Given this list of marker genes Gnb3, Gng8, Gng11, Plcb3, Gng7, Gnb2, Gng5, Gngt2, Gng10, Gng3, Gng4, Gngt1, Gnb5, here is a description of the gene set: Reactome Pathway: G beta:gamma signalling through PLC beta studied in species Mus musculus part of: G-protein beta:gamma signalling electronically inferred by orthology from the curated human pathway This event has been computationally inferred from an event that has been demonstrated in another species.<p>The inference is based on the homology mapping from PANTHER. Briefly, reactions for which all involved PhysicalEntities (in input, output and catalyst) have a mapped orthologue/paralogue (for complexes at least 75% of components must have a mapping) are inferred to the other species.